Given this list of marker genes TRAJ56, PNRC1 (proline rich nuclear receptor coactivator 1), CMPK1, RALGPS2, PIGK, CCR7, ZMAT3, BCL7A, ERGIC3, TNIK, C16orf74, H2AC8, UBA52, H4C6, RBBP7, PIAS2, LINC00402, SORL1, TRAJ37, TRBV6-1, TRBJ2-1, SPTBN1, AP3M2, NUCKS1, SPTAN1, ZNF266, SLC16A1, ANKRD36B, SH3YL1, ABCD2, TRAV38-1, CPSF6, EVL, TRAF1, PAFAH2, CAMLG, CTC1 (NCBI Gene Id 80169), SNORD59A, EIF3H, TRAJ11, SNORD30, PRKCQ-AS1, PLCL1, ZDBF2, TRAV41, P2RY10, WDR89, AGL, PYHIN1, PDCD4-AS1, TRGJP1, CDCA7L, SNORA18, KCTD7, ADAM28, AFF3, GID8, CD52, NAP1L1, MATK (megakaryocyte-associated tyrosine kinase), GAS5, MS4A1, IKZF3, PRSS23, SLC35E2A, MALAT1, CRY1, TRBV28, H1-1, PREPL, CAMK4, TRDC, SIRPG, THEMIS, PECR, LRPPRC, RPS20 (ribosomal protein S20), SLC41A1 (NCBI Gene Id 254428), PDE4DIP, ADGRE3, CCR6, MAGEH1, CLSTN3, SLC9A3-OT1, VWA8, CD3G, CDK6, MYO1D, CHRM3-AS2, ATP8B2, NEO1, SCAI, LTB, ZNF600, ATP8A1, PCNX1, CCNT1, GPA33, ZNF84, RPS6, BPTF, RETREG1 (reticulophagy regulator 1), EEF2, CBX5, TRBV6-5, PRKACB, CLEC2D, RPS29, RNF157, PAX5, EIF2S3, TRAJ30, SNORD36C, RBL2, MARCHF9, STXBP5, CD5, PDCD4, CRIPT, FLNB (NCBI Gene Id 8413), TRAV25, RSL24D1, ZNF486, TRAJ17, GPR174, CDC25B, PALS2, KIAA0586, TRBV20-1, POLA1, AKR1C3, FBL, PDZD4, ADPRM, BMI1 (NCBI Gene Id 648), CD8B, ZAP70, RGMB, SLC4A10, SLA2, MAML2, EPRS1, H4C13, PARP16, SIDT1, ATOSA (NCBI Gene Id 56204), HPCAL4, AGMAT, NOA1 (NCBI Gene Id 84273), TRGV2, CASS4, ACO1, AQP3, GCSAM, TRG-AS1, CRYL1, SLC12A2-DT, RPS21, SLAIN1, EIF4EBP2, TRAV27, POLR1E, FGFBP2, TRBC2, SLC7A8, H3C1 (NCBI Gene Id 8350), PM20D2, DENND4C, TCL1A, EIF3F, RPL27A, SCARNA6, APBB1, GNLY, RPL8 (ribosomal protein L8), CHMP7 (NCBI Gene Id 91782), HIBADH, KLRB1, SOD1 (superoxide dismutase 1), LINC01278, CA5B, SRSF8, TRBV27, IARS1, NUP88, DANCR, SNORD101, SLFN13, DHRS3, FOXP1, TRAJ5, TRGJP2, NLRC3, SNX25, H2BC7, CDC14A, PRRC2B, RPL32, FAM219B, FCRLA, RPS3, TRAJ36, IL23A, TMEM168, GYPC, HACD3, CFAP97, DTD2, PRPS1, POLR2B, TRAV29DV5, ZNF559, WEE1, RAPGEF6, PPWD1, CSDE1, BCL11B, PHB2, DENND11, RPLP2, ARB2A, MSI2, MTFMT (NCBI Gene Id 123263), SBNO1, DENND2D, SKAP1, SYNE1, ITK, MAGED1, AK5, GPATCH11, THRA, FCRL3, TRAV17, LAX1, SNRNP200, NPM1, TRBV5-6, DLGAP1-AS1, TRDV2, CCL5, FHIT, YAE1, RPL11, TSTD1, ZMYND11, ZBTB16, CD2, TTC3 (tetratricopeptide repeat domain 3), LYRM7, FITM2, SRPK2, CDKN2AIP, SAMD3, ZNF420, CRTC3, SNORD104, DPH5, CASP6, ZNF43, GARRE1, LAT, PCNX2, SLC38A1, TNRC6C, ARHGAP12, IGHM (NCBI Gene Id 3507), TRAJ48, ZNF91, PLXDC1, ZNF609, TRAJ33, TRAV12-1 (NCBI Gene Id 28674), HERC1, S1PR1, H4C5, SNORD33, ANKH, RPL37, EIF2D, TRAJ18, ZNF280D, RPL15, CNOT6L, PABPC4 (NCBI Gene Id 8761), KLRC2, CASK, ANAPC1, BLK, H2AC20, APEX1, PIK3IP1, CTSF, RPL17, APBA2, MGAT5, CEP95, TRBV9, MYBL1, TOB1, PDGFC, FOCAD, RHOH, COQ10A, ABHD14B, IFT46, GCNT4, RPA1, MBNL2, TRAV5, KLRG1, LDLRAP1, FBXO32, SNORD6, CRTAM, RPL29, PIK3C2B, SNORA16A, LCK, EIF3D, KLF12, TRAJ32, PFDN5, CCL28 (C-C motif chemokine ligand 28), ACVR2A, RORA, MSH2, RACK1, LRBA, TSPYL2, IL18RAP, SCML4, HINT1, TRAV21, LUC7L3, PDE3B, SYNRG, ANAPC15, TOP1MT, EEF1A1, EIF3K, CCNG1 (NCBI Gene Id 900), MACF1, ZNF836, ZNF286A, RPPH1, SEL1L3, PSIP1, MAPK13, LINC02397, SNORD15B, MPHOSPH9 (M-phase phosphoprotein 9), YEATS4, PTGDR, NSG1, HLA-DOB, SLC5A3, GRAP, TRMT2B, CD248, RPL35A, CYFIP2, CD44, ELP2, RPS6KA3, TRAV4, H2AC11, TAF9B, NFATC3, PDK1, CEP78, ITGB3BP, RPS15, NSA2, H4C8, RPL5, EIF3M, NAA16, ANAPC16, ZKSCAN8, CD79A (NCBI Gene Id 973), METTL16, RBMX, TRAJ42, CAMK1D, EPHX2, FOXO1, CYP27A1, DGKA, PPIA, ACP6, LDHB, LINC02210, GZMK, PBXIP1, TRAV16, NDUFAF4, VPS13A, ACADSB, AGTPBP1, ELP1, CRIM1, URI1, TRAJ14, TRAV9-2, FCRL6, NEPRO, PGM2L1, SLC16A10, EOMES, SCARNA5, KLRK1, EIF4A2, OSBPL10, TRAV1-2, TRAV13-2, PRKCQ, PLEKHB1, IFFO2, SATB1, ZEB1, RASA3, PTPN4, EEIG1, NAE1, CD247, TRAJ21, TRAJ9, P2RX5, NET1, CERS4, EXOSC8, ESYT1, ABI2, RPL22, ATP2B4, NR1D1, SLC7A6, ALDH18A1, RPL30, XPOT, CARD11, SNORD79, CCSER2, IKZF2, ZNHIT6, IGF1R, KLRF1, LANCL1, CD28 (CD28 molecule), USP34, RPS4Y1, FAM168B, ST6GALNAC6, DNAJB1 (DnaJ heat shock protein family (Hsp40) member B1), RPL26, SCARNA17 (NCBI Gene Id 677769), LRRN3, SLC12A2, OXNAD1, FBXL20, AHNAK, H4C1, RMRP, N4BP2, NPAT, SMIM8, TLE1, TCP11L2 (NCBI Gene Id 255394), AHCTF1, H2BC15, PCED1B, CENPV, PET117, CD6, TSEN54, TRGC2, SCARNA7, HECTD1, CD1C, NELL2, SEPTIN1, LIAS, FCRL1, LINC00649, ZBTB25, CXCR4, SNORA27, EPHA4, ADK, BACH2, AAK1, TOP2B, HLA-DQA1, ZNF292, SMYD3, SNHG5, IL2RB, TRAJ20, ZNF639, ARL4C, MFGE8, TDP1, RAB39B, CEP68, GNPDA2, NMUR1 (NCBI Gene Id 10316, neuromedin U receptor 1), OGT, OFD1, TRAJ47, PABPC1, TRAV13-1, EIF3J-DT (NCBI Gene Id 650026), TCF7, EEF1G, BRWD1, GOLPH3L, ITPKB, ARHGEF9, TRAJ24, LINC00861, HADH, KDM3A, ERMP1, PRDX2, UBE4B, SNHG1, IP6K1, MRPL48, BCL2, H2AC6, LEF1-AS1, NUCB2, AMY2B, SNHG29, CERK, H2BC10, SNORA5A, MZT2A, ZNF585B, SLC4A7, SP4, DSC1, CEP128, ZNF507, SNORD97, SUN2, KLRD1, EIF3E, CD96, PCID2 (NCBI Gene Id 55795), TRAV38-2DV8, TSPAN18, SLC16A7, TXK, RFX7, KCNA3, ZKSCAN3, MRPS6, RBL1, STAT4, TRBV5-1, TRAJ45, CXCR5, MFHAS1, USE1, BAG2, PRKDC, ZFP36L2, TC2N, DLG1, TRAV3, TBC1D10A, CD244, CST7, SCARNA2, TRBV24-1, RPL13, BTG1, TRBV19, SLC25A23, RRM1, LINC00938 (NCBI Gene Id 400027), ZNF792, TRGV8, ZNF101, CD200, RPL3 (NCBI Gene Id 6122), GPX7, DPP4, BIN1, USP53, EMB, TRABD2A, LEF1, EBF1, RPL24 (NCBI Gene Id 6152), C12orf57, HABP4, HMGB1 (high mobility group box 1), ZNF831, GNG2 (G protein subunit gamma 2), CDC14B, NIBAN3, SEMA4C (semaphorin 4C), RPS23, CD27, KMT2A, KLHL28, C1orf21, DTHD1, TRAJ57, PWAR5, TRGV3, MDN1, PLCG1, PDGFD, SSBP2, FCMR, TRBV4-2, ATPSCKMT, ZNF254, CD40LG, HEATR5B (HEAT repeat containing 5B), SNHG3, TBL1XR1, TRAV14DV4, CD3D, IGHV3-53, SNHG8, HSF2, WDCP, TRAJ8, TRMT61B, C12orf75, ALDOC, ZBED5-AS1, TRAV12-3, BBS9, CD79B, VNN1, RPL23, FCGBP, TRAJ13, H1-5, FAHD2B, CBLB, ZNF395, CD200R1, H2BC14, SH2D1B, KLHDC2, ARHGAP5, SFMBT1, RPL18, ATM, MID2 (NCBI Gene Id 286440), CHD3, SNORD116-14, TMEM204, SNORA61, LINC00920, TSPAN3, ANKRD36C, TIMM8A, DDHD2, CCDC7, TRAV26-1, CD8A, SFXN1, TRAJ16, TKTL1, WWP1, NFATC2, LTA4H, RPLP0 (NCBI Gene Id 6175), SIT1, RSL1D1, RASGRP1, ZFP82, H4C9, GSTM3, TRBJ2-4, RPLP1, RPS16, ESYT2, H4C3, ERN1, TRAV35, EZH1, RASA2, ITM2A, FAM107B, TRAJ3, ZNF32, LCLAT1, DOCK9, ZFAS1, MAN1A2, PRKCA, TRAV20, BBS2, TFDP2, CDR2 (cerebellar degeneration related protein 2), TTC39C, CD3E, TRBV10-1, HS3ST3B1, DYRK2, KAT6B, PLEKHF1, PCYOX1, AKT3, GALNT12, EIF4B, RPS5, CFAP68, SNORA6, IPP, ELAC1, TMEM106C, RPS18, PCED1B-AS1, HNRNPA3, ADNP, OTUD3, ABCC5, PAIP2B, COX11, ZNF181, TRDV1, PTPN22, UBR5, ATF7IP2, PRPF8, TFAP4, GLCCI1, HLA-DOA, PITPNC1, TRAJ27, BTLA, BDH1, MAP2K5, AFG2A, MAP3K14-AS1, IPO5 (importin 5), YPEL1, RPS19, LRIG1, STK17A, FCER1A (Fc epsilon receptor Ia), LINC00921, CEP57, TRBV6-4, TRBV2, IL16, PACS1, LIMA1, TRAV12-2, MBLAC2, SNORD4B, NMT2, DDX3X, SESN1, TRIB2, BCKDHB, ZC3H6, RPS13, TRGV9, GABPB2 (NCBI Gene Id 126626), RPS14, IL32, INTS6-AS1, CREBZF, CTSW, CYP2R1, TRAJ26, NR1D2, COMMD6, FUT10, TRBJ2-5 (NCBI Gene Id 28624), TRAJ22, PDE7A, TRAV8-2, CSNK1E, IL7R, ABLIM1, CASP8AP2, DIPK1A, CCNB1IP1, TMEM156, RGCC, ETS1, KPNA4, ZNF383, ZIK1, PTCH1, SNORA40 (NCBI Gene Id 677822), UBASH3A, PRKCH, CD7, RPL37A, WDR54, HLTF (helicase like transcription factor), ABCB1, TRAJ6, ZFP1, TRAT1, DCUN1D4, ABHD14A, TRAJ10, H1-3, RPL12, LBH, SACS, FMNL3, SEPTIN11, TMEM181, ST3GAL1 (NCBI Gene Id 6482), CEP120, RASGRF2, ITGA6, ZFP90, TRAV8-1, NT5DC1, TRAJ40, ST13, ZNF33B, TRAJ29, ZNF506, USP13, GPR171, SERINC5, TRAF5, GNG7, NDRG2, FAM169A, SNORD4A (small nucleolar RNA, C/D box 4A), TRAV8-6, RPL4, CNR2, SNORA68, MGAT4A, DUSP16, ANXA6, GZMA, SLC9A7, NOP53, TBC1D31, RAB30, VSIG1, EXOC6B, MAL, PATJ, TCEA3, TRBV11-2, CXXC5, CLK4, VEGFB, AXIN2, DLEU1, H3C11, TGFBR3, TRAJ34, MAP4K1, RECK, RCAN3, C14orf28, RNF125, MRPL45, TMEM14A, NR3C2, TRAV26-2, UXT, TRAV22, TUT4, ZBTB44, SPECC1L, RCN2, SVIP, TRAV23DV6, IMPDH2, ACVR2B, H3C4, ARID2, USP20, NDRG3, DDX6, PCMTD2, PHLPP2, MIB1, CD160, TIGIT (NCBI Gene Id 201633), NOL9, SLAMF6, NCAPD2, TIGD1 (tigger transposable element derived 1), EIF3L, TRAV19, SNORD26, TRAJ52, NCK2 (NCK adaptor protein 2), TRAC, TLR10, NCR1, TRBV5-4, ZNF329, MRTFB, NT5E, CCR4, CAD, LY9, TRAJ4, FYN, STK39, RPS15A, CDC42SE2 (CDC42 small effector 2), TOX, ZFP62, DIS3L, RCL1, NKG7, SESN3 (sestrin 3), RHOF, TRAJ41, NAA40, TRAJ12, CCND2, UNC119B, TRAJ38, TRBV3-1, COBLL1, LINC01128, PLEKHA1, TMEM116 (NCBI Gene Id 92920), DPEP2, TRAPPC2, ST6GAL1, SNORD57, MPRIP, SRSF5, MRPS27, TARBP1, IGHV4-34, NOG, NOL4L, ACSL6, DNAJC24, UBA2, RALGAPA1, UBTF, AKR1B1, HIVEP2, LINC01550, PLCB1, CFAP36, CBX7, TRIM52-AS1, INPP4B, GGTA1, RNF144A, ZNF337, PRORP, H2AC15, NCALD, ZFAND1, H2BC8, LDOC1, TSHZ1 (teashirt zinc finger homeobox 1), VPS51, H2AC17, SLC25A29, CASD1, PEBP1, TMEM97 (transmembrane protein 97), TCEAL8, NIPAL3, RPL35, BANK1, CYREN, RPS4X, RFLNB, NCAPD3, ARHGAP15, TRBJ2-2, ADGRG1, TRAV24, OCIAD2, SNORD15A, SH2D1A, IGHD, ELAPOR1, ATL2, TRAV2, CD22, ANP32B, SPOCK2, ZNF827, H2AC21, TESPA1, EPB41L4A-AS1, ENO2, H4C2, GSTM2, TRIM32, REST, THEM4, RPL6, H1-2 (H1.2 linker histone, cluster member), CSGALNACT1, TRAJ43, ZNF721, here is a description of the gene set: To better understand how innate immune responses to vaccination can lead to lasting protective immunity, we used a systems approach to define immune signatures in humans over 1 wk following MRKAd5/HIV vaccination that predicted subsequent HIV-specific T-cell responses. Within 24 h, striking increases in peripheral blood mononuclear cell gene expression associated with inflammation, IFN response, and myeloid cell trafficking occurred, and lymphocyte-specific transcripts decreased. These alterations were corroborated by marked serum inflammatory cytokine elevations and egress of circulating lymphocytes. Responses of vaccinees with preexisting adenovirus serotype 5 (Ad5) neutralizing antibodies were strongly attenuated, suggesting that enhanced HIV acquisition in Ad5-seropositive subgroups in the Step Study may relate to the lack of appropriate innate activation rather than to increased systemic immune activation. Importantly, patterns of chemoattractant cytokine responses at 24 h and alterations in 209 peripheral blood mononuclear cell transcripts at 72 h were predictive of subsequent induction and magnitude of HIV-specific CD8(+) T-cell responses. This systems approach provides a framework to compare innate responses induced by vectors, as shown here by contrasting the more rapid, robust response to MRKAd5/HIV with that to yellow fever vaccine. When applied iteratively, the findings may permit selection of HIV vaccine candidates eliciting innate immune response profiles more likely to drive HIV protective immunity. from publication Zak DE, Andersen-Nissen E, Peterson ER, Sato A, Hamilton MK, Borgerding J, Krishnamurty AT, Chang JT, Adams DJ, Hensley TR, Salter AI, Morgan CA, Duerr AC, De Rosa SC, Aderem A, McElrath MJ (PMID 23151505) Human Gene Set: ZAK_PBMC_MRKAD5_HIV_1_GAG_POL_NEF_AGE_20_50YO_1DY_DN Genes down-regulated in peripheral blood mononuclear cell 1d vs 0d in adults (20-50) after exposure to MRKAd5 HIV-1 gag/pol/nef, time point 1D. Comment: Table includes specific cell types studied in species Homo sapiens